Given this list of marker genes PDE12, RO60, IFNAR1, AXL, MYC (NCBI Gene Id 731404), PYHIN1, GAS6, FCAR, GATA3, TPR, OAS1, here is a description of the gene set: Any process that results in a change in state or activity of a cell (in terms of movement, secretion, enzyme production, gene expression, etc.) as a result of an interferon-alpha stimulus. Interferon-alpha is a type I interferon. studied in species Homo sapiens Human Gene Set: GOBP_CELLULAR_RESPONSE_TO_INTERFERON_ALPHA